Given this list of marker genes PSIP1, STMN1, LHX2, SOX4 (NCBI Gene Id 6659), STMN2, NEUROD1, TUBB, TUBB2B (tubulin beta 2B class IIb), MDM1, MAP1B, FEZF1, ELAVL4, CALB2, RTN1, PTMA, TUBA1A, MARCKSL1, ELAVL3, SOX11, MEX3A, GNG8, UCHL1, COTL1, H4C3, PCBP4, RPRM, NHLH1, HMGN2, HES6, H2AZ1, CKB, STMN4, JPT1, RBP1, EMX2, here is a description of the gene set: Human Gene Set: DURANTE_ADULT_OLFACTORY_NEUROEPITHELIUM_GLOBOSE_BASAL_CELLS studied in species Homo sapiens from publication Durante MA, Kurtenbach S, Sargi ZB, Harbour JW, Choi R, Kurtenbach S, Goss GM, Matsunami H, Goldstein BJ (PMID 32066986)